Given this list of marker genes Enoph1, Rcan3, Aptx, Inpp5j, Ppp3cb, Hsp90b1, Phactr4, Pip4p1, Ptpn2, Nt5dc2, Ptprv, Ppp1r14a, Dnajc6, Acp1, Ppp1r3a, Nt5c3b, Pald1, Mtmr7, Ptpn3, Enpp7, Ppp1r12a (NCBI Gene Id 71736), Calm1 (NCBI Gene Id 12313), Bmp2, Ppp2r5b, Calm2, Ppp3cc, Ppp2r2b (protein phosphatase 2, regulatory subunit B, beta), Epm2a (NCBI Gene Id 380675), Pnkp, Lmtk2, G6pc1, Ppp1r3b, Mdp1, Armt1, Ppp4r3b, Dusp9, Ptpn23, Enpp1 (NCBI Gene Id 97628), Elfn1, Igbp1b, Ppp4r3c2, Fbp1, Fra10ac1, Dusp10, Cdc25b, Ppp2r1b, Bpnt2, Ppp3r2, Ppp1r14b, Cdc14a, G6pc2, Eya3, Dusp3, Sbf2, Acp3, Ubash3b, Nt5c1a, Plpp7, Ppp1r3e, Ppm1a, Rngtt, Ptpn14, Phlpp2, Inpp5a, Ptp4a1, Ptprc, Rcan2, Ppp1r27, Acp2, Cdc14b, Nt5dc1, Ptk2, Ublcp1, Dusp6, Ptprt, Ppp4r4, Ptprr, Inpp1, Mgat5, Ppp1r7, Ptprm, Dusp21, Ppm1h, Ppp1r10, Ptpn4, Noct, Phospho2, Ppm1b, Ppp1r12b, Pfkfb4, Nit1, Nt5m, Ppp4r3c1, Dusp16, Ctdspl, Dusp18, Entpd3, Pgam5, Pank4, Dusp4 (dual specificity phosphatase 4), Ptpn18, Dusp2, Phospho1, Akp3, Ppp3ca, Ptprk, Cry2, Synj2, Ppm1e, Bckdk, Dusp13b, Ppp1cb, Ppp5c, Eya2, Ppef2, Pip4p2, Ctdspl2, Ptpn9, Ppp2r5c, Gna12, Ptprn (protein tyrosine phosphatase receptor type N), Ppp2r2a, Nt5c1b, Csnk2a1, Acp6, Ptprq, Tpte, Ptpn5, Ppm1j, Ppp2cb, Ywhab, Impa1, Dusp12, Ptpra, Ppp1ccb, Prune1, Ppp1r2, Plpp2, Ptpmt1, Ocrl, 2810408A11Rik, Tiprl, Cip2a, Phlpp1, Nt5c3, Plppr2, Ptprh, Ppp1r14d, Ambra1, Ssh1, Tigar, Pabir2, Ppp2ca, Ptprd, Ppp1r12c, Dusp5, Sbf1, Acp4, Eya1, Hdhd2, Dusp7, Plppr5, Ptp4a3, Bmp2k, Ptpn12, Dusp22, Myoz1, Ppp1r11, Mtmr2, Ppp1r26, Plpp4, Nt5e, Inpp5e, Pdxp, Igfbp2, Nt5c2, Pdp2, Minpp1, Sirpa, Ppp1r1a, Ilkap, Ppp1r37, Mtmr6, Plpp3, Ppm1d, Tmem225, Tns1, Pgp (phosphoglycolate phosphatase), Itga1, Phactr3, Inpp5d, Pp2d1, Lpin2, Dusp15, Lpin1, Ppp6r3, Dusp23, Car3, Ptpn1, Acp7, Arpp19, Ppp1ca, Ptprf, Ppp1r16b, G6pc3, Ppp2r3d, Igbp1, Ptprn2, Fbp2, Inpp4a, Ppp1r14bl, Ppp1r1c, Ppp2r5a, Mtmr12, Cpped1, Ppm1g, Tescl (NCBI Gene Id 69301), Ptpro, Ppm1k, Ppp1cc, Ptpn20, Lck, Slc39a10, Inpp5k, Dusp14, Plpp6, Ptpn6, Elfn2, Ctdsp1, Mtmr3 (myotubularin related protein 3), Anp32e, Ppm1f, Styxl2, Sh3rf2, Rpap2, Pabir1, Lpin3, Cnep1r1, Ppp4r2, Ptn, Ywhae, Nt5dc3, Ppp1r36, Plpp5, Timm50, Dusp26, Phactr1, Alpl, Ppp4c, Mtmr10, Ppp1r15b, Eya4, Ppp1r14c, Ptpru, Tns2, Bpnt1, Synj1, Pfkfb1, Ppp2r1a, Mtmr4, Mtm1, Ephx2, Inpp5b, Ptprz1, Inppl1, Ppp1r8, B3gat3, Inpp4b, Calm3, Ptpn11, Wbp11, Styxl1, Sgpp1, Ctdsp2, Pfkfb3, Styx, Pfkfb2, Dusp29, Inpp5f, Ptprs, Dusp11, Nanp, Dusp13a, Lhpp, Ppp1r3d, Mtmr14, Mtmr11, Ensa, Ppm1n, Plpp1, Ssh3, Tns3, Plppr4, Psph, Hddc2, Nt5c, Ssu72, Dusp1, Tab1, Sacm1l, Ppp6c, Ppp2r5d, Cd33, Dusp8, Alpi, Ssh2, Ppp2r2c, Tesc, Phpt1, Pxylp1, Sgpp2, Smtnl1, Htt, Ppp2r2d, Ptpa, Ppm1l, Impa2, Ptprg, Ptpn22, Cdc25a (NCBI Gene Id 52289), Rcan1, Igfbp3, Dusp28, Ppm1m, Cdc25c, Vrk3, Cdca2, Ppp1r3c, Cdkn3, Ppp1r9b, Atp1a1 (ATPase, Na+/K+ transporting, alpha 1 polypeptide), Pptc7, Ctdp1, Plppr1, Ppp6r1, Ppp2r3a, Ppp4r3a, Mtmr1, Dusp19, Pdp1, Gtf2f1, Ppp1r16a, Fig4, Ppp1r15a, Acp5, Ptprb, Ppp1r35, Ppp4r1, Tprn, Ppp6r2 (protein phosphatase 6, regulatory subunit 2), Ppp1r1b, Dmpk, Ctdnep1, Styx-ps, Ppef1, Ptpre, Ppp1r17, Hsp90ab1, Ptpdc1, Pten, Ptpn7, Alppl2, Ptpn21, Ptp4a2, Ppp3r1, Pudp, Ptprj, Cmya5, Ppa2, Cabin1, Plppr3, Ppp2r5e, Uri1, Bod1, Ptpn13, here is a description of the gene set: Catalysis of the hydrolysis of a phosphoric monoester, releasing a phosphate. Mouse Gene Set: GOMF_PHOSPHATASE_ACTIVITY studied in species Mus musculus